The following is a description of a gene set: species: Mus musculus Catalysis of the hydrolysis of peptide bonds, driven by ATP hydrolysis. Mouse Gene Set: GOMF_ATP_DEPENDENT_PEPTIDASE_ACTIVITY, and this is the list of marker genes: Clpx, Spg7, Afg3l2, Lonp2, Afg3l1, Lonp1, Clpp, Yme1l1